Given this list of marker genes LEPR, ACACA (acetyl-CoA carboxylase alpha), PRKAA1, ADIPOR2, PRKAG1, CPT1A, ADIPOR1, PRKAB1, ADIPOQ, LEP, here is a description of the gene set: studied in species Homo sapiens Leptin and adiponectin Human Gene Set: WP_LEPTIN_AND_ADIPONECTIN